The following is a description of a gene set: Heme degradation studied in species Homo sapiens Human Gene Set: REACTOME_HEME_DEGRADATION, and this is the list of marker genes: BLVRB, GSTA1, ABCC2, ABCG2, HMOX2, SLCO1B1, ALB, UGT1A4, SLCO1B3, HMOX1, ABCC1, SLCO2B1, FABP1, BLVRA, UGT1A1